The following is a description of a gene set: The chemical reactions and pathways resulting in the breakdown of glycosylceramides, any compound formed by the replacement of the glycosidic hydroxyl group of a cyclic form of a monosaccharide (or derivative) by a ceramide group. species: Mus musculus Mouse Gene Set: GOBP_GLYCOSYLCERAMIDE_CATABOLIC_PROCESS, and this is the list of marker genes: Psap, Gba2, Prkcd, Gla, Lct, Galc, Gba1